The following is a description of a gene set: Human Gene Set: GSE7831_UNSTIM_VS_CPG_STIM_PDC_4H_UP from publication Iparraguirre A, Tobias JW, Hensley SE, Masek KS, Cavanagh LL, Rendl M, Hunter CA, Ertl HC, von Andrian UH, Weninger W (PMID 18029397) CpG 1826 binds to Toll-like receptor (TLR)9, whereas influenza virus PR8 activates pDC via TLR7. Differential stimulation of pDCs is expected to result in unique activation mechanism(s) leading to a different phenotypically and functionally matured pDC We used microarrays to detail the global programme of gene expression underlying the maturation process of pDC activated with CpG 1826 and influenza virus PR8. We identified a distinct expression profile of upregulated immunomediators. Genes up-regulated in plasmacytoit dendritic cells (4h): untreated versus CpG oligodeoxynucleotide 1826. studied in species Homo sapiens, and this is the list of marker genes: WDR43, SATB1, ABCG2, LTB, OTULINL, MUTYH, YWHAZ, MEMO1, IPO8, GIMAP1, OSBPL5, CD244, SEPTIN1, SNRK, TEN1, PON2, EEIG1, DHRS3, MCM7, OCIAD1, FKBP10, DNAJC2, CRY1, SHISA5, CNN2, RXYLT1, TES, TNFRSF9 (TNF receptor superfamily member 9), DHX9, NCAPH, ECI1, DGKA, UGCG, KDELR2 (NCBI Gene Id 11014), NFKB1, PRKCH, ARHGEF1, PFKP, SLC12A7, DDX1, SLC25A20, SIVA1, MCAM, JAK1, TAF1B, RANBP9, CA2, NUDT4, NSG2, NR4A1, CNDP2, TXNRD1, CITED2, RNF145, ATP1B3, CDC6, KRT71, EIF1AX, CDK2AP1, RAN, USP38, PLRG1, KLRK1, SUN2, CRIP2, LEF1, PIAS2, SKI, LAT2 (NCBI Gene Id 7462), ASB6, HIBCH, ARHGAP9, PRKAB1, PAX6 (NCBI Gene Id 5080), CYTH3, CD96, NFS1, IL4R, IDE, PRIM1, PAK2, ELOVL6, HMGB2, PLA2G5, CTSD, ACTG1, MLLT1, TUT7, ARTN, IRAG2, ITGAX, IGF2R (insulin like growth factor 2 receptor), KLHDC2, ACSS1, NRIP1, MAPK6, PAFAH1B1, ZFAND5, SNX14, SLC12A2, LCP1, TRAF1, ADSS2, DTX1, GYG1, PPP1CB, ATG16L1, PITPNC1, UBE2T, NDUFA8, CXCR5, POM121, ORC5, GALNT2, NCR1, CHCHD3, CEL, FCHO1, EZH2, BMAL1, GTSE1, SKIL, ZAP70, NFYB, H2AZ1, SYPL1, ENO1, ANKRD13A, SNAP47, RANBP1, FXYD5, ARAP3, BFSP1, ANXA2, VASP, ANGEL2, SLC20A1, NME1, DGCR2, ID2, ARRB1, TCF7 (NCBI Gene Id 6932), EPHX1, KRAS, CXXC1, TCEAL9, CDC20, RC3H2, ELAVL1, CHMP5, RACGAP1, NIFK, TMEM71, TGFA, CAB39, SPTBN1, GFI1, EIF4A3, RBL2, MYO1F, TTC27, TNFRSF1B, SGK1, TAB2, RASA3, PRRC1, PBX3, CFB, BZW2, ITGAV, GMFG, SPG21, GZMK, CDC25C, COTL1, PRDX6 (NCBI Gene Id 9588), PCBD2, RAP1GDS1, RCN1, PRC1, EMB, SMPDL3A, UBA2, ZNF347, SPRED2, TMEM62, STK10, HERC4, XRCC5, FTSJ3, CTSW (cathepsin W), SCAF8, CASP4, FASLG, ADORA2A, MAIP1, IDH3G, TFDP1, KMT5A, SPDL1